Given this list of marker genes SARS coronavirus, complete genome, GPC5, TMPRSS2, SDC2, NRP1, GPC6, SDC4, GPC4, N, SDC3, E, AGRN (NCBI Gene Id 389836), GPC3, CTSL, SDC1, S, HAVCR1, GPC2, ACE2, VCP, HSPG2, GPC1, FURIN, 3a, 7a, M, here is a description of the gene set: studied in species Homo sapiens This COVID-19 event has been created by a combination of computational inference (see https://reactome.org/documentation/inferred-events) from SARS-CoV-1 data and manual curation, as described in the summation for the overall SARS-CoV-2 infection pathway.<br><br>Coronavirus replication is initiated by the binding of S protein to the cell surface receptor(s). The S protein is composed of two functional domains, S1 (bulb) which mediates receptor binding and S2 (stalk) which mediates membrane fusion. Specific interaction between S1 and the cognate receptor triggers a drastic conformational change in S2, leading to fusion between the virus envelope and the cellular membrane and release of the viral nucleocapsid into the host cell cytosol. Receptor binding is the major determinant of the host range and tissue tropism for a coronavirus. Some human coronaviruses (HCoVs) have adopted cell surface enzymes as receptors, angiotensin converting enzyme 2 (ACE2) for SARS-CoV-2, SARS-CoV-1, and HCoV NL63. The receptor-bound S protein is activated by cleavage into S1 and S2, mediated by one of two host proteases, the endosomal cysteine protease cathepsin L and another trypsin like serine protease. Type II transmembrane serine proteases TMPRSS2 and TMPRSS11D have also been implicated in the activation of S protein of SARS-CoV-2. Host factors may play additional roles in viral entry (not annotated here). Valosin containing protein (VCP) contributes by a poorly understood mechanism to the release of coronavirus from early endosomes. Host factors may also restrict the attachment and entry of HCoV. part of: Early SARS-CoV-2 Infection Events Reactome Pathway: Attachment and Entry_9694614